The following is a description of a gene set: studied in species Homo sapiens Uptake and function of anthrax toxins Human Gene Set: REACTOME_UPTAKE_AND_FUNCTION_OF_ANTHRAX_TOXINS, and this is the list of marker genes: PDCD6IP, ANTXR1, MAP2K6, MAP2K7, CALM1, MAP2K4, FURIN, MAP2K3, MAP2K1, ANTXR2, MAP2K2